Given this list of marker genes NUP133, PB1, NUP54, RANBP2, POM121, AAAS, NUP50, NUP85, RAE1, NUP88, NUP62, NS, NUP42, PB2, NUP93, NUP37, NUP107, NP, NUP210, NUP43, NUP188, NUP58, KPNB1, NUP35, NUP214, PA, KPNA1, SEC13, NDC1, NUP155 (NCBI Gene Id 9631), SEH1L, NUP98, POM121C, NUP153, TPR, NUP205, NUP160, here is a description of the gene set: part of: Influenza Infection species: Homo sapiens Reactome Pathway: Transport of Ribonucleoproteins into the Host Nucleus An unusual characteristic of the influenza virus life cycle is its dependence on the nucleus. Trafficking of the viral genome into and out of the nucleus is a tightly regulated process with all viral RNA synthesis occurring in the nucleus. The eight influenza virus genome segments never exist as naked RNA but are associated with four viral proteins to form viral ribonucleoprotein complexes (vRNPs). The major viral protein in the RNP complex is the nucleocapsid protein (NP), which coats the RNA. The remaining proteins PB1, PB2 and PA bind to the partially complementary ends of the viral RNA, creating the distinctive panhandle structure. These RNPs (10-20nm wide) are too large to passively diffuse into the nucleus and therefore, once released from an incoming particle must rely on the active import mechanism of the host cell nuclear pore complex. All proteins in the RNP complex can independently localize to the nucleus due to the presence of nuclear localization signals (NLSs) which mediate their interaction with the nuclear import machinery, including the RanGTPase. However the signals on NP have been shown to be both sufficient and necessary for the import of viral RNA.